Given this list of marker genes IFITM1, EIF4A1, GJA1, CACHD1, CCNC, MTHFD1, RPS24, ZNF257, SEMA6A, RPL24, PODXL, HMGB2, POU5F1, HNRNPAB, LRRN1, TPX2, NASP, FAM83D, SEPHS1, TUBB, CDK1, MGST1 (microsomal glutathione S-transferase 1), MAD2L2, RPL4, LIN28A, CRIPTO, CYP26A1, GNL3, NPM1, HDAC2, HMGA1, TK1, SNRPF, CALU, JADE1, PSMA2, EPRS1, SMS, GAL, AURKB, PSIP1, DTL (denticleless E3 ubiquitin protein ligase homolog), TNNT1, CCT8, GSX1, NME2, IGF2BP2, SFRP2, DDX21, SERPINH1, KPNA2, PITX2, RCC2, RPLP0, GDF3, NANOG, KRT8, CCNB1, IMPDH2, PSMA3, TNNC2, PTTG1, MTHFD2, SSB, FABP5, ARL5B, HSPA4, RPL6, KIF4A, OR7E33P, ELOVL6, CRABP1, SET, RPL7, BRIX1, SLC16A1, DSG2, IDH1, SRSF7, LDHB, RPSAP44, TUBB6, RSL24D1, ZNF43, here is a description of the gene set: The 'stemnes' signature: genes up-regulated and common to 6 human embryonic stem cell lines tested. species: Homo sapiens Human embryonic stem (huES) cells have the ability to differentiate into a variety of cell lineages and potentially provide a source of differentiated cells for many therapeutic uses. However, little is known about the mechanism of differentiation of huES cells and factors regulating cell development. We have used high-quality microarrays containing 16 659 seventy-base pair oligonucleotides to examine gene expression in 6 of the 11 available huES cell lines. Expression was compared against pooled RNA from multiple tissues (universal RNA) and genes enriched in huES cells were identified. All 6 cell lines expressed multiple markers of the undifferentiated state and shared significant homology in gene expression (overall similarity coefficient > 0.85).A common subset of genes was identified that included Nanog, GTCM-1, connexin 43 (GJA1), oct-4, and TDGF1 (cripto). Gene expression was confirmed by a variety of techniques including comparison with databases, reverse transcriptase-polymerase chain reaction, focused cDNA microarrays, and immunocytochemistry. Comparison with published stemness genes revealed a limited overlap, suggesting little similarity with other stem cell populations. Several novel ES cell-specific expressed sequence tags were identified and mapped to the human genome. These results represent the first detailed characterization of undifferentiated huES cells and provide a unique set of markers to profile and better understand the biology of huES cells. from publication Bhattacharya B, Miura T, Brandenberger R, Mejido J, Luo Y, Yang AX, Joshi BH, Ginis I, Thies RS, Amit M, Lyons I, Condie BG, Itskovitz-Eldor J, Rao MS, Puri RK (PMID 15070671) Human Gene Set: BHATTACHARYA_EMBRYONIC_STEM_CELL